Given this list of marker genes Smarcal1, Smarca1 (NCBI Gene Id 93761), Zranb3, Recql, Hnrnpa1, Rad54l, Trp53, Anxa1 (annexin A1), here is a description of the gene set: An activity that facilitates the formation of a complementary double-stranded DNA molecule. studied in species Mus musculus Mouse Gene Set: GOMF_DNA_DNA_ANNEALING_ACTIVITY